Given this list of marker genes FYN (FYN proto-oncogene, Src family tyrosine kinase), ADORA1, NTSR1, TRPV1, HTR2A, TAC4, SCN9A, DISC1, PRDM12, SCRN3, PHF24, ITGA2, MMP24, NR2F6, TAC1, COMT, KCNA1, ASIC3, SCN1A, SCN11A, EPHB1, TNF, ANO1, BACE1, LXN (latexin), NTRK1, CXCL12, TMEM120A, TRPA1 (transient receptor potential cation channel subfamily A member 1), here is a description of the gene set: The series of events involved in the perception of pain in which a stimulus is received and converted into a molecular signal. studied in species Homo sapiens Human Gene Set: GOBP_DETECTION_OF_STIMULUS_INVOLVED_IN_SENSORY_PERCEPTION_OF_PAIN